The following is a description of a gene set: species: Homo sapiens Human Gene Set: GOCC_ENDOPLASMIC_RETICULUM_TUBULAR_NETWORK_MEMBRANE The membrane of the endoplasmic reticulum tubular network., and this is the list of marker genes: ATL1, ATL2 (atlastin GTPase 2), RTN4, LNPK, ATL3